Given this list of marker genes CYBB, TM7SF2, IRF7, CCL7, PPP1R3B, PRELID2, PDE4DIP, SLC25A6, MGAT4A, LMAN2, SNX20, CLN5, VEGFA, STAT3, PARP3, IL13RA1, TANC2, UBE2F, DNER, SIGLEC7, ABCA1, PYGL, PIP5K1A, AKAP7, NUDT19, TRAPPC14, ZDHHC21, ACSL5, NCBP1, RNF19A, ABHD16A, ATP5MC3, P4HA2, PIK3R5, CMKLR1, AACS, MCEMP1, MET, DRAM1, FAM177A1, ACP5, NFE2L2, CNNM2, ACP3, MLF2, AP2S1, AARS1, CARD19, SLC44A1, PTK2, SLC31A2, FASN, NME6, CYBA, VPS37A, PPP1R21, GTF2E2, AP3M1, CYB5A, ABCF2, RPS6KA4, SMOX, AFP, SLC37A4, ATP5MC1, GPR132, ING1, FKBP15, CEBPD, TPST2, PDCD11, SPINT2, GBGT1, CDV3, EGR2, TRAF1, LSS, SAMSN1 (SAM domain, SH3 domain and nuclear localization signals 1), CIAPIN1, KLHDC10 (kelch domain containing 10), RNF149, METAP1, CFLAR, TRAPPC6A, ZNF821 (NCBI Gene Id 55565), CS, TKT, ZDHHC18, MMP19, PKM, MRPL54 (mitochondrial ribosomal protein L54), PRSS8, CCDC125, RNF128, MPHOSPH10, NPEPPS, TXNDC11, RNF181, RAP1GDS1, ISG15, C12orf42, PLEK, BCAT2, JAK1, ME2, NFYC, SCAMP5, CCL17, MKKS, CRELD2, MARCHF1, LYPD6, WNT9B, SDF2L1, HEXIM1, ABCA3, RLF, STK40, ISOC1, PKNOX1, HVCN1, EMILIN2, P2RX4, AOAH, HCAR2 (NCBI Gene Id 338442), MRPL52, ADCK5, ATOX1, NRP2, PRKCD, MTHFD2L (methylenetetrahydrofolate dehydrogenase (NADP+ dependent) 2 like), DNAJB6, ISCU, UAP1 (NCBI Gene Id 6675), UBASH3B, LITAF (lipopolysaccharide induced TNF factor), VRK3, PSMB10, BCL3, ADAM17, TIMM10B, TWF1, USP18, VPS36, COMTD1, TESK2, ARHGEF37, GNL3, HLA-DQA1, PARP9, WSB2, FAM98B, SDHD, PAG1, NUFIP1, SART3, PLGRKT, NFKB2, PECAM1, DNAJB1, DNAJC3, LPCAT3, ARRDC2, AHR (NCBI Gene Id 196), SYN1, CMTR1, EGLN3, TRAF2, SQOR, DOCK1, SUN1, KLF7, ATXN7L1, TRAPPC10, BSCL2, UGCG, TAGLN2, CEBPB, DNAJC21, ABHD17C, ST6GALNAC6, EGR1, SLC13A3, GBP2, MANF, DCAF1 (DDB1 and CUL4 associated factor 1), DNAJB2, SLC11A1, PLEKHA8, ITGAM, PDPN, TOR1AIP1, SQLE, CLEC6A, ZNF292, EIF3B, BNIP2, HRAS, CTSK, PSMD1, here is a description of the gene set: Genes down-regulated in plasmacytoid dendritic cells: wildtype versus TCF4 knockout. Human Gene Set: GSE24726_WT_VS_E2_2_KO_PDC_DN species: Homo sapiens from publication Ghosh HS, Cisse B, Bunin A, Lewis KL, Reizis B (PMID 21145760) The interferon-producing plasmacytoid dendritic cells (PDC) share common progenitors with antigen-presenting classical dendritic cells (cDC), yet they possess distinct morphology and molecular features resembling those of lymphocytes. It is unclear whether the unique cell fate of PDC is actively maintained in the steady state. We report that the deletion of transcription factor E2-2 from mature peripheral PDC caused their spontaneous differentiation into cells with cDC properties. This included the loss of PDC markers, increase in MHC class II expression and T cell priming capacity, acquisition of dendritic morphology and induction of cDC signature genes. Genome-wide chromatin immunoprecipitation revealed direct binding of E2-2 to key PDC-specific and lymphoid genes, as well as to certain genes enriched in cDC. Thus, E2-2 actively maintains the cell fate of mature PDC and opposes the “default” cDC fate, in part through direct regulation of lineage-specific gene expression programs.